The following is a description of a gene set: Mouse Gene Set: GOBP_TRANSCYTOSIS The directed movement of endocytosed material through the cell and its exocytosis from the plasma membrane at the opposite side. species: Mus musculus, and this is the list of marker genes: Lrp2, Rab5a, Picalm, Mfsd2a, Gpihbp1, Vps35 (NCBI Gene Id 65114), Rab11b, Fshr, Gp2, Lrpap1, Lrp1 (low density lipoprotein receptor-related protein 1), Uso1, Fcmr, Cltc, Pllp, Rab11a (RAB11A, member RAS oncogene family, NCBI Gene Id 53869), Cd300lg, Pigr, Ager, Tg, Ptafr, Igf1r, Src, Rab17